Given this list of marker genes ASPM, SVIL, CAMSAP3, CAMSAP2, CAMSAP1, NUMA1, ABRAXAS2, here is a description of the gene set: The end of a microtubule that does not preferentially grow (polymerize). species: Homo sapiens Human Gene Set: GOCC_MICROTUBULE_MINUS_END